Given this list of marker genes Gli1, Ttc21b, Ttll1 (tubulin tyrosine ligase-like 1), Pantr2, Map2k1, Kndc1, Gli2, Skor2, Cbln1, Lhx1, Usp9x, Atp7a, Cacna1a, Nrxn1, Whrn, Smo, Cdk5, Serpine2, Slc25a46, Gba1, Agtpbp1, Kif14, Ulk1, Cend1, Prox1, Tuba1a, Psap, Nfix, Comt, Coq8b, Dll1, Wnt7a, Lhx5, Rora, Herc1, Atxn2, Atp2b2, Mtpn, Sptbn2, Zfp365, Pcnt (NCBI Gene Id 97665), Ophn1, Ldb1, Faim2, Cntnap2, Grid2, Trnp1, Ptpn11, Foxp2, here is a description of the gene set: studied in species Mus musculus Mouse Gene Set: GOBP_CEREBELLAR_CORTEX_MORPHOGENESIS The process in which the anatomical structure of the cranial nerves are generated and organized. The cerebellar cortex is a thin mantle of gray matter that covers the surface of each cerebral hemisphere. It has a characteristic morphology with convolutions (gyri) and crevices (sulci) that have specific functions. Six layers of nerve cells and the nerve pathways that connect them comprise the cerebellar cortex. Together, these regions are responsible for the processes of conscious thought, perception, emotion and memory as well as advanced motor function.